The following is a description of a gene set: species: Mus musculus Mouse Gene Set: GOBP_MODIFIED_AMINO_ACID_BIOSYNTHETIC_PROCESS The chemical reactions and pathways resulting in the formation of compounds derived from amino acids, organic acids containing one or more amino substituents., and this is the list of marker genes: Slc27a1, Ckmt2, Gatm, Mthfs, Ckmt1 (NCBI Gene Id 12716), Mthfsl, Slc1a1, Gclc, Plscr1, Atic, Slc1a2, Cryaa, Bbox1, Hagh, Gch1, Eif2ak3, Plod2, Plod3, Acadm, Ckb, Mthfd1, Ggt6, Ggt7, Mthfd1l, Gclm, Ptdss2, Ckm, Park7, Gss, Fpgs, Dhfr, Chdh, Gart, Ggt1, Gamt, Slc46a1, Slc7a11, Aldh7a1, Mgst2, Ptdss1, Aldh9a1, Nfe2l2, Folr1, Ggt5 (gamma-glutamyltransferase 5)